The following is a description of a gene set: The process in which tubulin alpha-beta heterodimers begin aggregation to form an oligomeric tubulin structure (a microtubule seed). Microtubule nucleation is the initiating step in the formation of a microtubule in the absence of any existing microtubules ('de novo' microtubule formation). studied in species Mus musculus Mouse Gene Set: GOBP_MICROTUBULE_NUCLEATION, and this is the list of marker genes: Slain2, Haus2, Hspa1a, Mzt1, Ckap5 (NCBI Gene Id 97044), Pde4dip, Nin, Nedd1, Slain1, Nde1, Pak1, Tpx2, Tubgcp6, Pcnt, Tubgcp2, Mecp2, Tubgcp5, Tubgcp4, Golga2, Cep192, Ccdc66, Akap9, Eml2 (echinoderm microtubule associated protein like 2), Nme7, Clasp2, Tubg1, Tppp, Csnk1d, Cenpj, Dctn1, Arhgef7, Hspa1b, Tubg2 (tubulin, gamma 2), Clasp1, Tubgcp3, Ndel1, Git1, Ssna1, Ccdc57